Given this list of marker genes Insc, Wnt9b (wingless-type MMTV integration site family, member 9B), Pax6, Pou5f1, Aspm, here is a description of the gene set: Mouse Gene Set: GOBP_REGULATION_OF_ASYMMETRIC_CELL_DIVISION species: Mus musculus Any process that modulates the frequency, rate or extent of asymmetric cell division.